The following is a description of a gene set: Mouse Gene Set: GOBP_NONASSOCIATIVE_LEARNING A simple form of learning whereby the repeated presence of a stimulus leads to a change in the probability or strength of the response to that stimulus. There is no association of one type of stimulus with another, rather it is a generalized response to the environment. studied in species Mus musculus, and this is the list of marker genes: Drd5, Atp1a3, Htr2c, Grin2b, Epm2a, Shank1, Drd1, Mapk8ip2, Htr2a, Dgki, Kalrn, Ckap5, Comt